The following is a description of a gene set: The movement of a granulocyte in response to an external stimulus. studied in species Homo sapiens Human Gene Set: GOBP_GRANULOCYTE_CHEMOTAXIS, and this is the list of marker genes: SAA1, THBS4, TRPV4, PIK3CD, RAC1, DPEP1, MPP1, GBF1, EDN2, CXCL13 (NCBI Gene Id 115545), CCL4L2, CCL11, THBS1, PIK3CG, IL1B, S100A9, PDE4B, CCL16, CD74, ITGB2, CAMK1D (NCBI Gene Id 57118), S100A12, TNFSF18, IL17RA, CXCL9, C3AR1, CCL5, EDN1, AKIRIN1 (akirin 1), MOSPD2, CXCL3, CCR7, PERP (NCBI Gene Id 64065), TREM1, PPIB, CCL1, CXCL6, BST1, CCL3, VAV1, CXCL10, CKLF, C5AR2, CSF1R, JAM3, FCER1G, IL34, PF4V1, MAPK1, PIP5K1C, CX3CL1, CD300H (CD300H molecule (gene/pseudogene)), RIPOR2, PIKFYVE, CCL8, CCL22, NCKAP1L (NCK associated protein 1 like), CCL13, PPIA, C1QBP, CCL7, TIRAP, LBP, IL17RC, MCU, DPP4, C5AR1, CXCL17, CCL2, BSG, XCL1, MIR223, CCL4, CCL27, PPBP, CCL24, RAC2, ITGA9, PF4, CMKLR1, CCL21, S100A14 (S100 calcium binding protein A14), CCL25, CCL28 (NCBI Gene Id 56477), SYK, PTK2, PTPRJ, CCL26, SLAMF1, DAPK2 (NCBI Gene Id 23604), CXCR1, CSF3R, CXCL8 (C-X-C motif chemokine ligand 8), PREX1, S100A7, VAV3, VEGFA, MDK, LGALS3, MSTN, JAML, TNFAIP6 (NCBI Gene Id 7130), RARRES2, ADGRE2, MAPK3, IL23A, SRP54, S100A8, CCL19, ITGA1, DNM1L, EDN3, TGFB2, ANXA1, CXCR2, PLA2G1B, CXADR (NCBI Gene Id 95792), CXCL5 (C-X-C motif chemokine ligand 5), SCG2, SLIT2, CSF1